The following is a description of a gene set: Human Gene Set: AGCATTA_MIR155 studied in species Homo sapiens Genes having at least one occurence of the motif AGCATTA in their 3' untranslated region. The motif represents putative target (that is, seed match) of human mature miRNA hsa-miR-155 (v7.1 miRBase)., and this is the list of marker genes: ZBTB18, HBP1, SGK3, SPI1, MECP2, NUFIP2, ATP2B1, DYNC1I1, STRN3, ITK, KCNN3 (NCBI Gene Id 95947), SDCBP, RAB6A, RCN2, CUX1, C3orf18, CEBPB, TIMM8A, HIVEP2, ARL5B, SEMA5A, BACH1, LCORL (ligand dependent nuclear receptor corepressor like), ZNF236, DNAJB1, CAMTA1, ARID2, WBP1L, CD47, CELF2, UBE2D3 (ubiquitin conjugating enzyme E2 D3), IKBKE, GPR85, ACVR2A, ZFP69, SKI, SP3, OGN, TP53INP1, G3BP2, PTPN2, KBTBD2, MYB (MYB proto-oncogene, transcription factor), CREBRF, ANTXR2, HDAC4, ZMYM2, BRD1, HIF1A, YWHAE, CAB39, MYO1D, RREB1, PSKH1, SLC39A10, DNAJB7, KRAS, SYPL1, SSH2, PCDH9, CNTN4, SERAC1, GDF6, PDE12, BCORL1, BOC, CDC73, LRP1B, RAB11FIP2, MARCHF7, MAP3K14, ACTA1, TRIM2, ZIC3, ZNF518B, VEZF1, S1PR1, SOX1, TSPAN14, SLA, RAB1A, CHD7, WWC1, N4BP1, LINC03122, FAM135A, LRRC59, SEPTIN11, SOCS1, SMARCA4, NFIX, QKI, SATB1, MEIS1, FBXO33 (F-box protein 33), TSHZ3, ETS1, NFAT5, CTLA4, BCAT1, FGF7, NDFIP1, NOVA1, RNF123, PKIA, SOX11, TAB2, GPM6B, PICALM, ELL2 (NCBI Gene Id 22936), UPP2, SCG2, TLE4, ZNF652, YWHAZ, CSF1R, GOLPH3L, INPP5D, SGCZ, TOMM20, H3-3A, MYO10, FGF7P6, FAR1, UBE2W, MAP3K10, WEE1, FBXO11, BCAP29, PSIP1, CSNK1G2, RPS6KA3, CARHSP1, MIDN